Given this list of marker genes FDXR, SULF1, GPM6B, EFNB2, PRKCB, HEPH, MMP11, ZMAT3, PDE8B, ART4, SPCS3, PLP1, COL5A2, TFAP2C, DDB2, TGOLN2, CCND1, NAV2, FN1, COL3A1, MFAP2, ERCC3, LTBP2, ITM2C, TRPS1, COL4A1, IGSF3, COL9A2, HTR2B, PLAAT1, COL1A1, LOXL2, SATB2, SOX4, TYMS (NCBI Gene Id 7298), TMSB15A, CRMP1, EDNRA, COL4A2, MEST, ZFYVE9, STARD13, IGF2, HSD17B6, here is a description of the gene set: Uterine fibroids are some of the most common tumours of females, but relatively little is known about their molecular basis. Several studies have suggested that deletions on chromosome 7q could have a role in fibroid formation. We analysed 165 sporadic uterine fibroids to define a small 3.2 megabase (Mb) commonly deleted region on 7q22.3-q31.1, flanked by clones AC005070 and AC007567. We also used oligonucleotide microarrays to compare the expression profiles of 10 samples of normal myometrium and 15 fibroids, nine of which displayed 7q-deletions. Activating transcription factor 3, patched homolog (Drosophila), homeo box A5, death-associated protein kinase 1, and retinoic acid receptor responder 3 were downregulated, and excision repair crosscomplementing 3, transcription factor AP-2 gamma and protein kinase C beta 1 were upregulated in fibroids. New pathways were discovered related to fibroid formation. The presence or absence of 7q-deletions did not dramatically affect the global expression pattern of the tumours; changes, however, were observed in genes related to vesicular transport and nucleic acid binding. species: Homo sapiens from publication Vanharanta S, Wortham NC, Laiho P, Sjöberg J, Aittomäki K, Arola J, Tomlinson IP, Karhu A, Arango D, Aaltonen LA (PMID 15940248) Human Gene Set: VANHARANTA_UTERINE_FIBROID_UP Genes up-regulated in uterine fibroids vs normal myometrium samples.